Given this list of marker genes DGUOK, XDH, ADA, GDA, PNP, here is a description of the gene set: Human Gene Set: GOBP_PURINE_DEOXYRIBONUCLEOSIDE_METABOLIC_PROCESS species: Homo sapiens The chemical reactions and pathways involving any one of a family of organic molecules consisting of a purine base covalently bonded to a sugar deoxyribose (a deoxyribonucleoside).